The following is a description of a gene set: A limitation of the ability to place the forearm in a position such that the palm faces anteriorly (supination) and to place the forearm in a position such that the palm faces posteriorly (pronation). Limited pronation/supination of forearm studied in species Homo sapiens Human Gene Set: HP_LIMITED_PRONATION_SUPINATION_OF_FOREARM, and this is the list of marker genes: ROR2, SMAD6, COLEC10, COLEC11, LMX1B, HOXA11, TBX5, MECOM, MASP1 (NCBI Gene Id 5648), MET, IFITM5